The following is a description of a gene set: Mouse Gene Set: GOCC_PICLN_SM_PROTEIN_COMPLEX studied in species Mus musculus A protein complex that contains pICln (CLNS1A) and several Sm proteins, including SmD1, SmD2, SmE, SmF, and SmG., and this is the list of marker genes: Snrpd1, Snrpf, Snrpd2 (NCBI Gene Id 69107), Clns1a, Snrpe, Snrpert (small nuclear ribonucleoprotein E, pseudogene), Snrpd3